Given this list of marker genes LDB1, GATA2, CASP3, MALAT1, GTF3C4, PLEK, IFITM2, EMP3, P2RX5, NDEL1, GSE1, FLNA, PTMA, SDF2L1, CANX, SLC40A1, IKZF2, MS4A3, RAB11FIP1, MS4A2, ATF4, TENT5A, GLUL, CSF2RB, ANXA1, GATA1, CCDC88A, CALR, DNAJC9, VASP, GOLT1B, PNMT, PPP1R15A, HDC, TES (testin LIM domain protein), GRAP2, CD63, PSME4, SLC25A3, ING2, POU2F2, SOX4, CD82, TOB2, PLGRKT, LMO4, SLC2A1, SEC24D, SLC6A6, HSPA5, PIM2, FOSB, MIR4435-2HG, STAM, FAM178B, FBXO7, S100A6, FBXO33, GDE1, MT-TL1, PABPC4, SPTY2D1 (NCBI Gene Id 144108), TIMM17A, LMNA, HSP90AB1, PDIA3, MLEC, TRIB2, SMIM1, TSPYL2, AFF2, LGALS1, CNRIP1, TFRC, LAPTM5 (NCBI Gene Id 7805), TFR2, PNN (pinin, desmosome associated protein), PLIN2, HMGCS1, NEDD9, CHPT1, VIM, ASRGL1, P4HB, S100A4, CTNNBL1, BRIX1, CHP1, TPSAB1, JUND, HPGDS, STAT5A, BACE2, TMSB10, LYAR, ALOX5AP, here is a description of the gene set: from publication Zheng S, Papalexi E, Butler A, Stephenson W, Satija R (PMID 29545397) species: Homo sapiens Human Gene Set: ZHENG_CORD_BLOOD_C2_PUTATIVE_BASOPHIL_EOSINOPHIL_MAST_CELL_PROGENITOR